The following is a description of a gene set: electronically inferred by orthology from the curated human pathway Reactome Pathway: SUMOylation of DNA replication proteins This event has been computationally inferred from an event that has been demonstrated in another species.<p>The inference is based on the homology mapping from PANTHER. Briefly, reactions for which all involved PhysicalEntities (in input, output and catalyst) have a mapped orthologue/paralogue (for complexes at least 75% of components must have a mapping) are inferred to the other species. part of: SUMO E3 ligases SUMOylate target proteins studied in species Mus musculus, and this is the list of marker genes: Nup210, Nup42, Nup93, Top2a, Pcna, Seh1l, Aurkb, Nup155, Sumo1, Nup58, Nup205, Nup133, Aaas, Ndc1, Nup54, Nup85, Rae1, Pias4